Given this list of marker genes CDKN1A, CCNI, PLAGL1, ITGB1, ZNF274, ECT2, CDK6, CCND3, TGFB2, RB1 (NCBI Gene Id 92728), TP53, FGF1, PDGFA, MYCN, ELK3 (ETS transcription factor ELK3), AKT2, MAF, here is a description of the gene set: studied in species Mus musculus Genes up-regulated in the intestine after the tissue specific knockout of PTEN by Cre-lox. Human Gene Set: HE_PTEN_TARGETS_UP from publication He XC, Yin T, Grindley JC, Tian Q, Sato T, Tao WA, Dirisina R, Porter-Westpfahl KS, Hembree M, Johnson T, Wiedemann LM, Barrett TA, Hood L, Wu H, Li L (PMID 17237784) Intestinal polyposis, a precancerous neoplasia, results primarily from an abnormal increase in the number of crypts, which contain intestinal stem cells (ISCs). In mice, widespread deletion of the tumor suppressor Phosphatase and tensin homolog (PTEN) generates hamartomatous intestinal polyps with epithelial and stromal involvement. Using this model, we have established the relationship between stem cells and polyp and tumor formation. PTEN helps govern the proliferation rate and number of ISCs and loss of PTEN results in an excess of ISCs. In PTEN-deficient mice, excess ISCs initiate de novo crypt formation and crypt fission, recapitulating crypt production in fetal and neonatal intestine. The PTEN-Akt pathway probably governs stem cell activation by helping control nuclear localization of the Wnt pathway effector beta-catenin. Akt phosphorylates beta-catenin at Ser552, resulting in a nuclear-localized form in ISCs. Our observations show that intestinal polyposis is initiated by PTEN-deficient ISCs that undergo excessive proliferation driven by Akt activation and nuclear localization of beta-catenin.